The following is a description of a gene set: Any process that modulates the rate, direction or extent of axon growth such that the correct diameter is attained and maintained. species: Mus musculus Mouse Gene Set: GOBP_REGULATION_OF_AXON_DIAMETER, and this is the list of marker genes: Wnt7a, Kel, Nefl (neurofilament, light polypeptide), Xk, Gla, Nefm, Cntn2